The following is a description of a gene set: from publication Feuerer M, Herrero L, Cipolletta D, Naaz A, Wong J, Nayer A, Lee J, Goldfine AB, Benoist C, Shoelson S, Mathis D (PMID 19633656) Genes down-regulated in comparison of lymph node conventional T cells versus fat tissue conventional T cells. Human Gene Set: GSE7852_LN_VS_FAT_TCONV_DN species: Homo sapiens Comparisons of global gene-expression profiles revealed a greater distinction between CD4+ Treg cells and CD4+ conventional (Tconv) T cells residing in abdominal (epidydimal) fat versus in more standard locations such as the spleen, thymus and LN., and this is the list of marker genes: ARHGAP21, NFKBIZ, MDFIC, SEC24D, CASS4, SAP30, VCL, PQBP1, PNP, HCST, NFIL3, IQGAP1, STX3, LRRK1, ZC2HC1A, SNIP1, ITGA1, ALAS2, RORA, MECOM, PLP2, LGALS1, ZNF622, TTC19, CASP1, ATF3, NKG7, ASB1, LUM, ANXA2 (NCBI Gene Id 792), PPP1R15A, DIPK2A, GAS7, FOSB, RNF128, BAG3, CEMIP2, IFITM2, COL3A1, CXCL3, MPRIP, TOB1, PKD2, ZFP36L2, CXCR3, PRDM1, SIK1, CCR2, BEX2, CTNNA1, TTC39C, ZNF212, PYGL, SOCS2, AR, RXRA, BEX3, ODC1, IGF2, FBXO30, FASLG, RAI2 (retinoic acid induced 2), KCNK5, IL1RL1, AHCY, METRNL, FARP1, MYADM, DUSP5 (dual specificity phosphatase 5), TMED9, S100A4, CYB561, ANTXR2, MMP9, ZBTB42, SLC16A6, CLTC, ESM1, KCTD12, GPSM1, FANCF, RGS2, AXIN2, IL10, LMNB1, RIPK1 (receptor interacting serine/threonine kinase 1), CDC42EP3, SYNE3, STIM2, SLCO4A1, HIVEP2, SRSF7, SNCA, CDKN1A, NFATC2, RYR1, ABCB1, ENTPD1, CFD, DENND4A, EHD4, HSPA5, CAMK2N1, DPY19L1, ITSN1, CBLB, AKAP13, SOD2, ARHGAP26, ZCCHC10, TNFSF14, KLF9, BCL2L1 (BCL2 like 1), IER3, TNFRSF18, NR4A2, EFEMP1, ATP2B4, NR4A1, TBX21, INPPL1 (inositol polyphosphate phosphatase like 1), GPX8, TAX1BP3, KHNYN, ABLIM3, PLEKHF2, PHF6, CORO2A, H2AZ1, TXN, HMGB2, NXPE4, S100A11 (S100 calcium binding protein A11), MYO1F, DCN, PDE7A, TJP2, HIGD1C, UHRF2, RNF19B, ORC1, PHF13, SORL1, RAPH1, HOPX, TSC22D1, FHL1, SLC25A28, TMEM64, EPSTI1, SPARCL1, SEMA3G, BCL2A1, USP27X, DENND4C, SNHG8, HSPA13, TAGLN2, HIP1, GZMB, CXCR4, ITGB1, BTG3, CUEDC1, KCNJ8, TMBIM1, IMPACT, SEMA4C, DPT, RAP1GAP2, PTPN9, COBLL1, NEDD4, PLS3, NIBAN1, ACYP2, IFNG, COL4A1, SAMSN1, NUDT4, TRIM13, PLEK, PRKRA, KLRG1, TSC22D2, MARVELD2, BHLHE40 (NCBI Gene Id 8553), DGKE, ATF4, DCAF5, P2RY10, RAB11FIP5, KLHL11 (kelch like family member 11), SLC2A3, SMAP1, CDR2, DENND5A, JCAD (junctional cadherin 5 associated), RUNX3 (RUNX family transcription factor 3), AGPAT4